The following is a description of a gene set: Any process that stops, prevents, or reduces the frequency, rate or extent of signal transduction mediated by the ERK1 and ERK2 cascade. Human Gene Set: GOBP_NEGATIVE_REGULATION_OF_ERK1_AND_ERK2_CASCADE studied in species Homo sapiens, and this is the list of marker genes: EZR, DLG1, SIRT3, PSCA, CHRNA9, TLR4, RPS6KA6, SPRY1, PIN1, DAB2IP, ERRFI1, TBC1D10C, SPRED2, MIR185, MIR221, EMILIN1, ITGB1BP1 (NCBI Gene Id 9270), KLF4, DAB2, WNK2 (NCBI Gene Id 65268), ACE2, SMAD4, ABL1, SPRY3, ATF3, SIRPA, LYN, PTPRR, GPER1, DUSP10, IGF1, DUSP7, SPRY4, MIR200C, SPRY2, SEMA6A, CSK, EIF3A, SPRED3, LIF, NLRP6, MIR138-1, LMO3, MIR503, MIR133A1, XBP1, C3orf33, GSTP1, MIR205, NLRP12, SPRED1, PHB1, VRK3, BTN2A2, MIR424, TLR9, CRYBA1, DUSP4, NHERF1, SYNJ2BP, ADIPOQ, MIR133B, RGS14 (regulator of G protein signaling 14), CHRNA10, NDRG2, DUSP26, TNIP1, MIR21, FLCN, DUSP9, EPHA4, PTPN2, DUSP29, PTPRC, DUSP3, CNKSR3, DUSP1, EPHB2, GBP1, FBLN1, PTPN1, DUSP6, C1QL4, RANBP9